The following is a description of a gene set: Any protein maturation process achieved by the cleavage of a peptide bond or bonds within a protein. Protein maturation is the process leading to the attainment of the full functional capacity of a protein. species: Homo sapiens Human Gene Set: GOBP_PROTEIN_PROCESSING, and this is the list of marker genes: CASP8, MEP1A, CTSH, DHCR24, HID1, PCSK9, METAP2, SNX12, VSIR, HM13 (NCBI Gene Id 92622), DPP4, GSN, PREP, FXN, PARP1, NKD2, CLN3, CORIN, HGFAC, ADAMTS13, KLK1, LRRK2, SPCS1, CPE, ZMPSTE24, APH1B, NAGLU, F9, PSEN1, PRKACB, CTSG, P2RX7, MBTPS1 (membrane bound transcription factor peptidase, site 1), PISD, RUNX1, PGK1, TLL1, MYRFL, APH1A (aph-1 homolog A, gamma-secretase subunit), PRSS12, IFT52, SHH (NCBI Gene Id 6469), ATG4B, ADAM19, CASP7, TMPRSS2, ADAM17, CAPN2, MIR152, SCG5, PCSK5, GGT2P, F3, ADAMTS3, KEL (NCBI Gene Id 3792), ADAMTS2, IMMP2L, MYRF, MMP16, CPD, ADAM8, C1RL, GLI3 (NCBI Gene Id 2737), XPNPEP3, PLA2G7, ACE2, SERPINE2, YIPF5, PCSK4, RHBDD1, KLK6, SPG7, DHH, SDE2, MMEL1, ECEL1, CASP4, REN, ADAM10, CASP2 (caspase 2), DYNC2H1, SERPINE1, PCSK7, NLRC4, TMEM208, ASTL, MAGEA3, CTSZ, OGT, GGT1, AFG3L2, TMPRSS12, ENPEP, ATG4A, CASP3, SIRT4, C2CD3, KLK13, TLL2, SRGN, CLEC3B, APOH, PLG, MYH9, TMPRSS4, TMEM98, F11, RCE1, PIDD1, NLRP7, H2BC1, FGG, ACE (NCBI Gene Id 654142), CPM, F7, ECE2, PIK3C3, PLAT, KLK3, HPR, HJV, ATP6AP2, USP17L2, IMMP1L, ADAM9 (ADAM metallopeptidase domain 9), CPA3, CUZD1, PCSK2, TNP2, MIPEP, SERPINF2, LONP2, PRSS37, CCBE1, GAS1, CLN5, PLAUR, CMA1, CSTL1, RPS6KA2, COMP, DISP1, S100A10, CTSL, MDM2, STOML2, MAFB, PRNP, SPON1, YME1L1, IL1R2, MME, PRKACA, ENO1, ATP23, PCSK1, CASP6, SPCS2, SRC, ANPEP, PTCH1, ACP4, C1R, INPP5B, SLC30A8, CHAC1 (NCBI Gene Id 79094), KLKB1, BACE2, SPCS3, NCSTN, LGMN, SPPL3, LDLRAD3, THBD, SLC30A5 (solute carrier family 30 member 5), PLGRKT, HP, CTSS, FKRP, RNF139, ERO1B, OMA1, FGA, ATG4D, SPRTN, ASPRV1, HPN, DDI2, SEC11C, CASP1, ANXA2, PLAU, RFX4, PSENEN, AEBP1, GLG1, CASP9, MBOAT4, PRSS3, TYSND1, ECE1 (NCBI Gene Id 1889), BAG2, KLK2, SEC11B (NCBI Gene Id 648643), CWH43, BCHE, FAM111A, CPN1, MMP14, PCSK1N, IHH, PRCP, FURIN, PMPCB, MELTF, THBS1, PMPCA, HTRA2, IFT172, CPZ, ATG4C, TNP1, SEC11A, PSEN2, FGB, EEF1AKMT4-ECE2, P4HB, PITRM1, ACTMAP, ANGPTL8, BACE1, MYC, CNTN2, CPLANE2, PHEX, PCSK6, PARL, F12, BMP1